The following is a description of a gene set: species: Homo sapiens from publication Shinohara H, Behar M, Inoue K, Hiroshima M, Yasuda T, Nagashima T, Kimura S, Sanjo H, Maeda S, Yumoto N, Ki S, Akira S, Sako Y, Hoffmann A, Kurosaki T, Okada-Hatakeyama M (PMID 24833394) Human Gene Set: GSE41176_UNSTIM_VS_ANTI_IGM_STIM_BCELL_24H_UP The activation signaling of transcription factor nuclear factor-kB (NF-kB) plays central role for immune system. One of key kinase mediating this pathway is TAK1 in adaptive and innate immunity. However, role of TAK1 in B cell receptor signaling is still unclear. To know effects of TAK1-deletion on the gene expression induced by anti-IgM, we performed the time course analysis in comparison of wild type with TAK1-deleted splenic B cells. Genes up-regulated in B lymphocytes: untreated versus anti-IgM for 24h., and this is the list of marker genes: KIT, PCDH17, MROH1, IL22, ADARB1, MARVELD1, UEVLD, RAC3, VSIG1, SAXO2, CACHD1, HLF, SLC4A7, FLNC, RORC, PLEKHF1, ROGDI, GLCCI1, POLN, SERPINB1, CXCL13, HLX, OTOF, PXDC1, FAM25C (family with sequence similarity 25 member C), TSSK4, AQP3, GABRP, DUSP15, KBTBD13, PTPRN, IL1R1, SCG2, VEGFA, SLC34A3, NAV1, ANXA8, PPM1H, LIPC, PTGFR, CNTN1, ZNF423, TIMP2, SCRN1, PC, KRTAP4-3 (NCBI Gene Id 85290), ZNF317, SLITRK5, TREH, TMIGD1, SMIM5, SLC6A18, RAMP1, ADAM21, TGM5, MBOAT4, EPB41L5, GPR18, RNF152, THEMIS2, HS3ST2, STX11 (NCBI Gene Id 8676), ENPP5, MFAP5, NHSL2, ATP6V1E2, WFDC5, EFHC1, WIPI1, HSPB1, CTPS2, HECW1, KIF5C, STAC2, TTLL7, KCNMB4, SLC25A24, TMEM176A, CCL20, VANGL1, FBXO44, FBXO27 (NCBI Gene Id 126433), HNF4A, TMED7, CPNE8, VSX2, SLC11A1, TEAD3, MOV10, SEC14L2, MYT1, TMEM123, FAM110C, RUSC2, SEPTIN12, FOXN1, FBXO41, TLR8, KBTBD7, KCNF1, IL17RE, ZNF76, MS4A8, CLRN1, ZNF600, RASA4, BNIPL, COL5A1, TRIM40, PIEZO2, SEC24A (NCBI Gene Id 10802), AHDC1 (AT-hook DNA binding motif containing 1), ACSM3, NOXO1, POPDC2, CPB1, DBN1, OLFML2A, VPREB3, FXYD1, LYSMD2, EFCAB11, TMCO5A, NPTX2 (NCBI Gene Id 95714), SLC6A15, PLCB4, CBFA2T3, OPRL1, ELOVL3, C2CD4B, DEGS2, HS3ST6 (NCBI Gene Id 64711), KCNC3, HEY1, CRAT, LAMA5, CPE (carboxypeptidase E), PCDH9, ADORA3, TUBA8 (tubulin alpha 8), SLC8A1, DBH, PRSS44P, C16orf96, NMT2, FAM3C, TMEM176B, ANGPTL2, TFF3, PRG3, RTL8B, MID1, DCDC2, CPNE5 (copine 5), CHST10, ZNF572, DCST1, TMEM200A, USP50, CIT, DNAI2, NOS1, AHSG, SFRP1, AMOTL1, TSPAN32, AGBL4, ATXN1, KLK7, GABRG2, FAM216B, CD300C, AMH, NKX2-6, CYP4F22, TCF15, MYRF, PRKAG3, SERPINA12, TEX47, AKAIN1, SIAE, TDRKH, ST8SIA2, HYDIN, POU4F2, C1orf116, GCGR, TPPP3, PSIP1, DAB2, SERPINB6, RAB27B, TBC1D16, TUT4, OXT, COL1A2, USP33